The following is a description of a gene set: studied in species Homo sapiens Human Gene Set: HP_BROAD_TOE Visible increase in width of the non-hallux digit without an increase in the dorso-ventral dimension. Broad toe, and this is the list of marker genes: FGFR2, HOXD13, DNM1L, FGF9, GATA6, KIAA0753, WNT5A, SUMF1, SETBP1, GPC4, BMP2, TNNT3, GJA8, LBR, EP300, PRKG2 (NCBI Gene Id 5593), EFNB1, SATB2, POGZ, TRPM3, PPP2R1A (protein phosphatase 2 scaffold subunit Aalpha), ACAN, SIAH1, UBE2A, CCDC22, ROR2, SCNM1 (NCBI Gene Id 79005), CEP295, CREBBP, UBAP2L, NAA10, NEK1, HNRNPR, GPC3, BCOR, TAF6 (TATA-box binding protein associated factor 6), TWIST1, GDF5, CSNK2A1, TBCK, ZMYM2 (zinc finger MYM-type containing 2), SMARCA2, ALDH6A1, NKX2-6, KCNH1, USP9X, PYCR2, CDK10, EBP, C2CD3, ADNP, KMT2D, ABCC9, HPGD, ZEB2, FGFR3, SMC1A, RHOA, COL2A1, PDE4D, BMPR1B, NKX2-5, ASPH, LRP4, IFT122, FGFR1, DLX5, NPR2, NXN, KMT2B, IL11RA, SF3B4, DVL1, CHST11, ZMIZ1, GJA5, PIGL, TBX1, MEIS2, PUF60, FLNA, NOG (NCBI Gene Id 9241), BPTF, PIGO, NBAS, GLI3, WDPCP, MED12